Given this list of marker genes CAD, OTC, ASL, ASS1, SLC25A15, ATP5F1A, ARG1, SLC7A7, UMPS, here is a description of the gene set: An increased concentration of orotic acid in the urine. Oroticaciduria species: Homo sapiens Human Gene Set: HP_OROTICACIDURIA